Given this list of marker genes PTGFR, CHRM2, HTR2C, EDNRA, EDNRB, ITPR2, AGTR1 (angiotensin II receptor type 1), CYSLTR1, GNA15, GRPR, PLCB2 (NCBI Gene Id 5330), PTGER1, TACR2 (NCBI Gene Id 6865), PTGER3, HRH1, NTSR1, AVPR1A, PTAFR, GNAQ, OXTR, AVPR1B, CCKBR, TRHR, LHCGR, CHRM3, PLCB3, ADRA1D, BDKRB1, CXCR4, GRM5, TACR3, HTR2A, TBXA2R, CYSLTR2, ITPR1, BDKRB2, GNA14, CCKAR, LTB4R2, ADRA1A, CHRM1, F2R, TACR1, GRM1, HTR2B, ADRA1B, GNA11, PLCB1, PLCB4 (NCBI Gene Id 5332), ITPR3, here is a description of the gene set: Human Gene Set: KEGG_MEDICUS_REFERENCE_GPCR_PLCB_ITPR_SIGNALING_PATHWAY species: Homo sapiens GPCR-PLCB-ITPR signaling pathway. Pathway ID: N01640. Pathway type: Reference. Pathway class: nt06528 Calcium signaling. Pathway Definition from KEGG: GPCR -> GNAQ -> PLCB -> IP3 -> ITPR -> Ca2+(cyto)